The following is a description of a gene set: Genes up-regulated in comparison of germinal center B cells versus plasma cells. Human Gene Set: GSE12366_GC_BCELL_VS_PLASMA_CELL_UP from publication Longo NS, Lugar PL, Yavuz S, Zhang W, Krijger PH, Russ DE, Jima DD, Dave SS, Grammer AC, Lipsky PE (PMID 19023113) Sorted B cells using flow cytometry. CD19 selected B cells were sorted using flow cytometry. studied in species Homo sapiens, and this is the list of marker genes: MCM9, SNHG6, OSTF1, PHC2, CELF1, FERMT3, CALM2, ARL11, FNTA, PCNA, DLD (dihydrolipoamide dehydrogenase), MYL12B, CDCA4, SPC24, VRK1 (NCBI Gene Id 7443), SEMA4F, MCUB, SAE1, UVRAG, SF3B4, ROCK1, ZNF708 (NCBI Gene Id 7562), ADSL, FABP5, KDM2B, UBE2C, NAA38, OTULIN (NCBI Gene Id 90268), CMC4, TADA3, DTYMK, ARPC5, EXOSC10, GCNT2, MPZL3, INPP5B, BDP1, C9orf40, IARS1 (NCBI Gene Id 3376), EPS15, TUBA1C, LINC01138 (long intergenic non-protein coding RNA 1138), LY86, LARP4B, NCBP3, EEA1 (early endosome antigen 1), SNX29, CEP85L (centrosomal protein 85 like), BCL2L13, RBM14, UBE2I, URB2, MCM2, CDCA5, TOB2, PBX3, NUDT21, SNRPA, DCP2, RRM2B, TUBB3, NUP50, ADNP, RMI2, TMOD2, GMIP, NAP1L1, QSOX2, ARMC8, SMARCA4, CALM3, SGMS1, INTS15, TBC1D10C, SKAP2, INPP5D, ZFP36L1, PANK2, RAB33A, CPM, PTPRC, GINS1, IMPA2, RASGRP2, HSDL2, KCTD10, FAM106A, FIGNL1, CTDSP2, LCOR, DLEU2, LMCD1, SNX5, CAMK2D, PPP1R18, RNF144B, MGME1, KIF22, SNHG7, DAZAP1, GAR1, STAT5B, XYLT1, POTEKP, AP1AR, SKP2, KDM1B, MCM4, DDX23 (NCBI Gene Id 9416), STAG2, ETS1, TMEM106C, S1PR2, DTX1, RUVBL1, RAD21, WNK1, OFD1, CCNG2, FBXO38, YY1 (NCBI Gene Id 7528), NOP2, ZNF818P (NCBI Gene Id 390963), CYBB, SNRPD1, RAD51, MASTL, RCAN3, BUB1B, USF3, DPY19L2, ETV3, POLD3, ZHX2 (zinc fingers and homeoboxes 2), ITGB2-AS1, MED28, TOP2B, RPS27, POT1, EIF3F, TCL6, KPNA2, MKNK2, SH2B3, CCP110, SETD2, TXN2, VASP, CCDC18, CYP2U1, SUPT16H, RAB4B, ADD3, DMD, ZYX, UTP6, USP34, PTEN, TFAM, ARID4B, PGLS, TDP2, ZBTB44, POLD4, CRKL, GMFB, RPAIN, RAPGEF5, AEBP2, EEIG2, FCRL3, KCTD20 (NCBI Gene Id 222658), HYCC1, DUSP2, USP7, C16orf87, RNF19B, ENO1, CD22, GLMN, ESPL1, TP53, METAP2, PUM3, LDAF1, PRR14L, PUM2, TUBB2A, RPL21, HAUS6, BACH2, CD53, DHFR, TUBB4B, EEF1A1, PPP1R35, GCSAM